The following is a description of a gene set: A process in which a protein is transported to, or maintained in, a location within the nucleoplasm. studied in species Homo sapiens Human Gene Set: GOBP_PROTEIN_LOCALIZATION_TO_NUCLEOPLASM, and this is the list of marker genes: DKC1, LARP7, CCT7, CCT3, CCT2, TBRG1, CCT8, MEPCE, CCT4, CCT6A, CCT5, WRAP53, NOP53, TCP1